The following is a description of a gene set: Mouse Gene Set: GOBP_REGULATION_OF_EXOSOMAL_SECRETION Any process that modulates the frequency, rate or extent of exosomal secretion. studied in species Mus musculus, and this is the list of marker genes: Atp9a, Smpd3, Prkn, Vps4b, Atp13a2, Snf8, Sdc4, Hgs, Tsg101, Vps4a, Myo5b, Sdc1, Pdcd6ip (NCBI Gene Id 97504), Rab7, Stam, Sdcbp, Chmp2a